Given this list of marker genes ABCB1, ABCA1 (NCBI Gene Id 8371), ABCA2, ABCC1, ABCB4, here is a description of the gene set: Human Gene Set: GOBP_SPHINGOLIPID_TRANSLOCATION species: Homo sapiens The movement of a sphingolipid molecule from one leaflet of a membrane bilayer to the opposite leaflet.